Given this list of marker genes USP14, N, AGER, UBE2N, BIRC2, S100B, NFKB1, VRK3, UBE2D1, UBB, MAP3K8, NOD2, TIFA (NCBI Gene Id 92610), PPP2CA, RPS6KA2, IRAK1, NKIRAS1, ELK1, OPTN, TRAF6, SAA1, TAB1 (NCBI Gene Id 10454), PPP2R1B, TAB3, MAPKAPK3, CREB1, MAPK10, MAP2K3, DUSP7, APP, NFKBIB, BIRC3, ATF2, LRRC14, CUL1, PPP2CB, MAPK8, DUSP4, JUN, ATF1, TANK, SARM1, MAPK9, N4BP1 (NCBI Gene Id 9683), UBE2D2, MAPK3, RELA, MAPK1, IRF3, RPS6KA3, MEF2A, MAPK14, UBE2D3, TAB2, HMGB1, TICAM1, FADD, IKBIP, MAP2K6, DUSP3, IRAK2, IKBKG, S100A12, ALPK1, NLRC5, UBE2V1, MAPK7, NFKB2 (NCBI Gene Id 4791), DUSP6, UBA52, UBC, PPP2R5D, IRF7, TP53, MAP2K4, RPS27A, RIPK1, PPP2R1A, MAP2K7, RIPK3, IKBKB, MEF2C, RPS6KA5, BTRC, TRAF3, MAPKAPK2, MAP2K1, USP18, IKBKE, TRAF2, RPS6KA1, CASP8, MAP3K7, TNIP2, FBXW11, NFKBIA, TLR3, CHUK, NKIRAS2 (NFKB inhibitor interacting Ras like 2), FOS, MAPK11, TBK1, NLRX1, RIPK2, NOD1, SKP1, here is a description of the gene set: Toll-like receptor 3 (TLR3) as was shown for mammals is expressed in various tissues and cells, including myeloid dendritic cells, macrophages, respiratory and intestinal epithelium, neurons and microglial cells to induce antiviral and inflammatory responses of the innate immunity in combating viral infections.<p>TLR3 recognizes dsRNA in the endosome and that triggers the receptor dimerization. TLR3 recruits the adaptor TRIF (TICAM1), leading to the activation of NF-kappa-B and the production of type I interferons (IFNs). dsRNA-stimulated phosphorylation of two specific TLR3 tyrosine residues (Tyr759 and Tyr858) is essential for initiating TLR3 signaling pathways. species: Homo sapiens part of: Toll-like Receptor Cascades Reactome Pathway: Toll Like Receptor 3 (TLR3) Cascade